The following is a description of a gene set: Human Gene Set: GOBP_REGULATION_OF_MITOCHONDRIAL_MEMBRANE_PERMEABILITY species: Homo sapiens Any process that modulates the frequency, rate or extent of the passage or uptake of molecules by the mitochondrial membrane., and this is the list of marker genes: ATP5IF1, SLC25A6, BCL2L1, GSK3A, BAK1, MIR17, STAT3, RTL10, BCL2 (NCBI Gene Id 596), PMAIP1, TMEM102, SLC35F6, GCLC, IER3, MIR29B1, ZNF205, RHOT1, ARHGAP11B, LRRK2, THEM4, STPG1, BNIP3L, VDAC2, HK2, NOL3 (NCBI Gene Id 8996), PPIF, BLOC1S2, TP53, PPM1K, MIR29A, CAMK2A, ATF2, GSK3B, ACAA2, SPG7, MPV17L, HIP1R, MUL1, SIVA1 (SIVA1 apoptosis inducing factor), SLC25A5, BCL2L11, TMEM14A, MTCH2, MIR29C, BAX, NAIF1 (nuclear apoptosis inducing factor 1), CHCHD10, BAD, EYA2, BNIP3, SLC25A31, BID, ALKBH7, BOK, SLC9A1, HSPA1A, RHOT2, SLC25A4, FZD9